Given this list of marker genes Bnc2, Zfp800 (NCBI Gene Id 637385), Slitrk4, Mdga2, Inafm2, Atp10a, Slc31a1, Iars1, Cdc40, Zfp654 (NCBI Gene Id 72020), Tpd52, Pnrc2, Cmbl, Zmat2, Lats2, Clec4b2, Nrip3, Spire2, Cpne8, Rsf1, Rab21, Lhfpl2, Pbrm1, Sdc2, Rfc1, Zmym5, Efcab14, Nfyc, Acss1, Bpnt2, Bloc1s4, Fktn, Larp4, Amer2, Slc6a4, Letmd1, Rnf13, Rrbp1, Ctbp2, Mtmr9 (NCBI Gene Id 210376), Rps6kb1, Ppat, Aadat, Ing1, Slc41a2, here is a description of the gene set: from publication Chen Y, Wang X (PMID 31504780) species: Mus musculus Genes predicted to be targets of miRBase v22 microRNA mmu_miR_15a_3p in miRDB v6.0 with MirTarget v4 prediction scores > 80 (high confidence targets). Mouse Gene Set: MIR_15A_3P